The following is a description of a gene set: Neighborhood of MYC studied in species Homo sapiens Human Gene Set: MORF_MYC Neighborhood of MYC v-myc myelocytomatosis viral oncogene homolog (avian) in the MORF expression compendium, and this is the list of marker genes: CD6, CRHR1, HAUS5, ZNF330, HTR4, GRIP2, GRIK5, ITIH4 (NCBI Gene Id 3701), RASSF1, FDXR, PAX7, ADCYAP1, SLC13A2, SRSF8, DOK1, TBX5, STK17A, SLC22A24, SLC16A5, SLC30A3, RFC5, KRT33A, KYAT1, DRC3, PRELID3A (NCBI Gene Id 10650), MYC, BCL2, MC2R, PAXIP1, IPCEF1, RPS6KB2, TGOLN2, CLOCK, ABO, SLC5A2, NCKIPSD, ZKSCAN3, AQP5, CYP11A1, ENTREP1, KRT1, SLC4A3, TMEM94, SIX3, SCAPER, HTR7, SLC2A1, AMFR, MPP2, ITPR2, TNFRSF25, SSTR5, CEP135, PAX8, COLQ, ESR1, SLC6A9, LTBP4, PRSS16, MLN, GRK4, CDK5R1, F7, DPT, PIGB, MSX1, KRT86, DAPK2, PAX9, KLHL18, RPH3A, PLEKHB1, ZNF592, GLE1, RBBP8, HOXD4, NFIC, NFRKB, KAT8, MYO9B